The following is a description of a gene set: Human Gene Set: MIR6834_3P from publication Chen Y, Wang X (PMID 31504780) species: Homo sapiens Genes predicted to be targets of miRBase v22 microRNA hsa-miR-6834-3p in miRDB v6.0 with MirTarget v4 prediction scores > 80 (high confidence targets)., and this is the list of marker genes: APBB2, KRT10-AS1, NEUROD4, NTRK3, KRAS, NFYA, CAMK1G, KIF3C, ARL8B, FUT11, RUNX1, PHAX, UBLCP1, CRISPLD1, TBL1XR1, PDPR, KCTD1, FOXP2, COL19A1, MOB1A, DFFA, GCM2, H2BW1 (NCBI Gene Id 158983), IGF2BP3, SWSAP1, DDX20, ZFAND1, TP53INP1, MAGEA4, CNTNAP1, NKAPD1, SOHLH2, CENPN, RANBP10, DUT, MBTD1 (mbt domain containing 1), CPN1, NRG3, PFN2, NAA15, DNAJB9, ADAMTSL3, TM9SF3, PRAMEF18, NUCKS1, FAM135B, GBP3, SLC39A1